Given this list of marker genes PCLO, CCDC25 (NCBI Gene Id 55246), RSBN1, ENAH, TCEAL8, EEIG2, TMEM33, EML4, PLGRKT, ANTXR2 (NCBI Gene Id 118429), ARHGAP12, ECT2, SSH2, ACADM, NEK1, ZNRF3, SCAMP1, CPSF6, HERC3, BTBD7, SPTLC3, ANK3, DNAJB9, NEPRO, ZC3H12B, SCAF8, HTR2C, PRKDC, KCNH5, HECW1, SLC38A2, WDR11, RNF111, NR3C2, DGKH, NOTCH2NLA, SLC30A9, PPP4R2, PELI1, MBL2, HERPUD2, CDC73, PUM1, PCDH7, CNOT1, ARL13B, ABRAXAS2, TSSK2, ARL5A, PRKAA1, LIMCH1, MFSD14B, TAFA1, MYT1, OGFOD3, C5orf15, MSI2, FREM2, CADM2, TMF1, KLHL8, PLS1, DNAJC6, KRR1, EML6, MINDY2, DIRAS2 (NCBI Gene Id 54769), STXBP5, MDM1, PRPF40A, MEGF10, MRPS27, PHTF2, CAAP1, ZNF217, RDH11, C1orf174, IPO8, BAZ1B, OXCT1, AP1S3, MTMR10, REV3L, MYRIP, DCUN1D1, ARHGAP5, CCNT1, PDIA6, ZZEF1, CLIC4 (NCBI Gene Id 25932), PAX6, FAM3C, SCAI, PSMD14, MAP3K20, ASAP1, BLOC1S6, SPATA13, KCTD14, RBM26, ZCCHC14, PEX19, ZBTB14, CDC42SE2, LOX, TCF4, MEGF9, PRPF39, QKI, STK39, SGIP1, BLTP3B, MAGEF1, SNTB1, SLC12A3, YIPF6, RAB30, DCDC2, EIF3A, LTB, ELK4, ARMC3, LIX1, PSEN1, MIGA1, UBE2K, SLC19A4P, PDZD2, APPL2 (NCBI Gene Id 55198), TMEM30A, ACVR1C, NUFIP2, SERTAD4, YTHDF3, LNPK, SLC4A4, DENND1B, TCEA1, UBE2E2, FSIP1, CEP97 (NCBI Gene Id 79598), AAGAB, EPB41L4B, TOMM20, MBD2, TBC1D15, MDFIC, CALCR, PAG1, MIOS, ARL4A (NCBI Gene Id 10124), ATE1, ANOS1, PTER, RAPGEF5, ZNRF2, FBXO43, CMTR2 (NCBI Gene Id 55783), EDA2R, PIK3CG, SEC22C, CFAP65, SCG5, A1CF, WASF1, MAPK8, PLRG1, AIRIM, RYR2, ERO1B, ZBTB20, NADK2, SSR1, DYNC1LI1, BMP4, ZNF148, IRF2BP2, EGFLAM, REPS2, FAM218A, USP9X, ERBIN, ELAVL2, GABRA4, THUMPD1, DDX3X, SLC19A3, RP2, CEP43, NIPSNAP2, BARD1, PI4K2B, SMPX, CNKSR3, METTL23, NRSN1, FSD1L, MED23, FAM120A, UBXN2B (NCBI Gene Id 137886), MINAR1, TTC28, RAD54B, RFX3, RPL22L1, LRPPRC, PITPNM3, HOOK1, ZNF518A, JAZF1, TMX4, KCNT2, DDX4, TBC1D8B, PARP8, ARPP19, PHF6, KCND2, PTP4A1, DSE, CACNA2D1, FRMD5, SEC61B, ZC3H7A, PEX3 (NCBI Gene Id 8504), PRELID3B, LMOD1, FKBP7, ATP2B4, SLC18A2, DIP2C, C5orf24, PAIP1, HECTD2, TLE4, AMD1, DNAJC21, GLYR1, HNRNPC, KL, GPR37, MMD, TMX1, ZBTB44, TGFBR2, TMEM65, CNTNAP3B, LANCL3, MITD1, C1GALT1, TBL1XR1, MARK1, TMEM74, ANK2, AAK1, PCGF6, CCNC, TEF, GRM5, VWA2, NTF4, CNTN1, PLS3 (NCBI Gene Id 5358), RNF185, CUL4A, ATF2, PTPN21, SMIM10L1, PKD2L2, PEX5L, DR1, HNRNPR, PTEN, EIF1AX, PXN, PTS, MAN2A1, GAB1, SCLY, PTPN4, IGF1, CNTNAP3, PLA2G4C, TNFSF13B, HTR5A, LCORL, NIPBL, CRHBP, APH1A, DDX42, KPNA4, TMEM245, APPL1, ELAVL1, PPARGC1A, PLCL1, GID4, PLEKHH2, ARSJ, CRELD2, ZNF76, CREB3L2, TAB2, PDK3, CNIH3, KDSR, SGPP2, NRN1 (NCBI Gene Id 51299), SLC40A1, MBNL2, BDP1, ZMYM2, FAM20B, ITGA4, PSMB9, TWSG1, ELL2, ZFP36L1, UBE2V2, GOLIM4 (NCBI Gene Id 27333), C2CD4A, SP3, GLS, UBQLN2, SLITRK1, SLC4A10, GNG2, TRMT5, SRSF6, ART3, ZCCHC2, AJUBA, CTTNBP2NL, ROCK2, GALNT7, FUT9, SUZ12, OPN5, NTN1, OPRPN (opiorphin prepropeptide), FSBP, SLC31A1, BRWD3, MAB21L1, IKZF2, LEO1, XRN1, B4GALT4, HNF4A, SERPINB12, NETO1, LSM14A, SLC4A7, MTSS1, HMGCR, DIPK2A, BPTF, LNX2, CA10, RIPPLY3, ITGB8, TANC2 (NCBI Gene Id 80259), CSNK1A1, MLLT10, PRSS12, PHLDB2, AGO2, WWP1 (NCBI Gene Id 81891), ZNF451, PIK3CA, GJA3 (gap junction protein alpha 3), UBE2E1, CPEB4, PPM1A, SLC33A1 (NCBI Gene Id 9197), ENPP2, TPT1, THAP4, TOPORS, SNAP91 (synaptosome associated protein 91), DUSP10, WARS2, SH3BGRL2, KCNMA1, SMURF2, GHSR, DNAJB14, PRTG, LIN7A, ARHGAP29, MXI1, RASEF, PWWP3B, SLC30A4, ZDHHC6, KIAA1958, PPCS, SH3TC2 (NCBI Gene Id 79628), HP1BP3, CDC14A, CERT1, REST, KCNQ1, CNEP1R1, IMPACT, here is a description of the gene set: studied in species Homo sapiens Human Gene Set: MIR8063 Genes predicted to be targets of miRBase v22 microRNA hsa-miR-8063 in miRDB v6.0 with MirTarget v4 prediction scores > 80 (high confidence targets). from publication Chen Y, Wang X (PMID 31504780)